Given this list of marker genes IQSEC1, EXOSC7, AGPAT5, DCTD, AP1S2, GCKR (NCBI Gene Id 2646), CAMSAP1, OXTR (oxytocin receptor), RRM2, THSD7A, KLHL9, PGM1, CHST3, SCAI, YPEL5, TG, NUAK1, GPRC5A, MADD, PDZD8, HILPDA, PPFIBP2, PARN, IVNS1ABP, DIP2C, FSTL3, GRK6, SLC25A37, STX7, TFAP2C, ALLC, ASTE1, GPRC5C, JUND, TNKS, OTUB2, APPL2, CHST15, ZNF133, RRS1, TOR1B, PLAU, RHOQ, EXTL1, MRTFB, TGFA, RAP2C, PRSS23, CREB3L2, CASC3, SYNE1, PALLD, TTC3, UBR7, PIK3CD, SLC7A11, UBL3, RHOBTB1, SLC29A3, POGK, KCMF1, SMOX, CADM4, PTCH1, CERK, LAMC2, EPAS1 (endothelial PAS domain protein 1), ANKRD28, RNASEH1, ING4, PBX3, ZBTB1, ODC1, DLEU1, RBM15, KRT20, JAG2, MELTF, ADGRA3, TRAK2, DKK1, GRB10, DUSP14, FAM200C (family with sequence similarity 200 member C), POLR2C, ZFAND5, ARL4A, ADGRG1, AGO2, NFIB, LMCD1, CELP, FKBP15, SGK1, KIAA0232, TRAF3, TRAF1, C2CD2, FOXD1, MTFR1, SERTAD2, RNF139, NACC2, SPEN, DCLRE1A, KIF3C, PDE10A (phosphodiesterase 10A), PLPP1, MEGF9, MAPKAPK5-AS1, CCS, MARCKS, TOLLIP, MYBL1, MMP24, SRSF8, SEC16A, MCM3AP, DLC1, AZIN1, ZCCHC14, RASSF2, CNN2, NKRF, PAX9, GALNT10, CLIC3, TMEM120B, ZMIZ1, GDE1, PPP1R3C, PHF20, BAG5, MLLT11 (MLLT11 transcription factor 7 cofactor), CA9, C6orf120, RAP1GAP, ENO2, PPME1, TGFBR2, RGS3, PHLPP2, ATP2B1, TUG1, OSBPL11, PLEKHG3, PRKCA, COTL1, MRC1, ST3GAL5, IMP3, MYH10, SPRY2, MAN1A2, P3H4, MRAS, DERL1, TBL1X, GET1, SDC4, MEX3C, MAP3K9, COQ8A, UBN1, BFAR, UBL4A, AGAP1, CAMSAP2, GLDC, KANK2, ABL1, BAMBI, EPN2, SLC25A32, FAM114A1, DESI2 (desumoylating isopeptidase 2), FAM171A1, ARRB2, MFAP3, DTL, IFT81, SLC20A1, FBXW11, PAGE1, MYO5C, RYK, ZBED5, HNF1B, SOX9, EPHX3, RPE (NCBI Gene Id 96188), SQLE, AMIGO2, TSC22D1, FLAD1 (NCBI Gene Id 80308), PFKFB3, PMCHL1, MYL12A, here is a description of the gene set: studied in species Homo sapiens Genes up-regulated in T conv from: peripheral lymph nodes versus thymic precursors. Human Gene Set: GSE42021_TCONV_PLN_VS_TREG_PRECURSORS_THYMUS_UP from publication Toker A, Engelbert D, Garg G, Polansky JK, Floess S, Miyao T, Baron U, Düber S, Geffers R, Giehr P, Schallenberg S, Kretschmer K, Olek S, Walter J, Weiss S, Hori S, Hamann A, Huehn J (PMID 23420886) We investigated at which stage of maturation commitment to a stable Foxp3-expressing phenotype takes place. We assessed stability of Foxp3 expression in thymic Foxp3+ Treg subsets of different maturity, defined by CD24 expression. Next we compared gene expression profiles of Foxp3+ Treg subsets (+) of different maturity (24lo, 24int, 24hi) and could identify a set of genes that were specifically up or downregulated in Foxp3+ Tregs, but not in Foxp3- conventional T cells, in a maturation-dependent manner.